The following is a description of a gene set: studied in species Homo sapiens Any process that modulates the rate, frequency or extent of release of cytochrome c from mitochondria, the process in which cytochrome c is enabled to move from the mitochondrial intermembrane space into the cytosol, which is an early step in apoptosis and leads to caspase activation. Human Gene Set: GOBP_REGULATION_OF_RELEASE_OF_CYTOCHROME_C_FROM_MITOCHONDRIA, and this is the list of marker genes: TNFSF10, PPIF (NCBI Gene Id 10105), HRK, BID, BAX, OPA1, PLSCR3, GHITM, HIGD1A, PMAIP1, FAM162A, BAD, TRIAP1, BNIP3, PINK1, NOL3, BMF, HGF, IGF1, MMP9, PSMD10 (proteasome 26S subunit, non-ATPase 10), PLAUR, GPER1, PRKN, BCL2L11, IFI6, TP53, CLU, GPX1, MOAP1, BIK, PRELID1 (NCBI Gene Id 27166), AKT1, PARL, MLLT11, BCL2L1, BAK1, LMNA, PYCARD, FXN (frataxin), BBC3